The following is a description of a gene set: Genes containing one or more binding sites for (Sox30) in their promoter regions (TSS -1000,+100 bp) as identified by GTRD version 20.06 ChIP-seq harmonization. from publication Yevshin I, Sharipov R, Kolmykov S, Kondrakhin Y, Kolpakov F (PMID 30445619) species: Mus musculus Mouse Gene Set: SOX30_TARGET_GENES, and this is the list of marker genes: Gm5941, Bmp2k, Lrrc8d (NCBI Gene Id 75118), Lsm4 (LSM4 homolog, U6 small nuclear RNA and mRNA degradation associated), Ppa2, H2az2, Ube2v2, Dennd4b, Gm8127, Rnf4, Prdm4, Pacs1 (phosphofurin acidic cluster sorting protein 1), Repin1, Chd5, Prkcz, 0610040J01Rik, Slco6b1, Gm14204, Spata1, Ring1, Fndc3a, Fyb1, Cage1, Coro1c, Dstn, Hdgf, H2bc21, Sun2, 4930554H23Rik, Mrpl45, Gtsf1l, Zfp687, Gabra4, Gm6558, Cry1, Nudc, Gm34106, Mov10l1, Vezt, Gm20474, Glyr1, A230072C01Rik, Srsf11, Zc3h4 (NCBI Gene Id 330474), Gid4, Elovl2, Ero1a, Uba5, Mcts2, Cdc42, Ptpmt1, 4632404H12Rik, Fam178b, Mfsd12, Drap1, Dmrta2, Ppara, Shisa6, Map1lc3a, Sri, Tent5c, Eif5, Bicdl1, Glod4, Aptx, Mir3083, Gm27011, Lmnb1, Nr2f6, Spaca1, Klf15, Josd1, Chd1, Gm6526, Ythdf2, Rybp, Egr3, Nabp1, Exosc3, Usp2, St8sia6, Slc30a4, Dbil5, Spag4, Pnma1, Raver2, Eaf2, Cdkn1c, Adnp, Ica1, Dpy19l1, Fhl3, 1700104B16Rik, Ufsp2, Coro2b, Bop1, Pdcd2, Zfp217, 2610037D02Rik, Otud1 (NCBI Gene Id 71198), Gtf2h5, Sltm, Sphk2, Bbs5, Trafd1, Gm16464, Ube2o, Vldlr, Atpaf2, Prkacb, Cdca7l, Otud4, Nudt3, Adam22, Zfp276, BC034090, Gtf2e2, Prickle1, Gli3, Nelfe, Gabrb3, Dmrta2os, Trim24, Stard10, Ift70a2, Zbtb25, Prpf40a, Cmip, Ccnb2 (NCBI Gene Id 235460), Prpsap1 (NCBI Gene Id 67763, phosphoribosyl pyrophosphate synthetase-associated protein 1), Tubd1, Tulp4, Phospho1, Aff3, Marchf6, Mnt, Siva1, Ash1l, Strbp, Hmgb1, Ppp1r3e, Clgn, Eif4a2, Foxf2, E130317F20Rik, 1110059E24Rik, Chka, Spata7, Ccdc96, Zfp37, Grb10 (NCBI Gene Id 67977), Slc22a23, Dcdc2a, Eif5b, Mex3c, Klhdc3, Papola, Tmem225, Mcl1, Macroh2a1, Bap1, Prdm15, Stac, 4930406D18Rik, Rassf1, Eif4g2, Ddhd1, Vars1, Paxbp1, Wnk2, H2ac18, Fnip2, Gm16576, Dhx15 (DEAH-box helicase 15), Stk11, Mir5131, Shq1, Knop1, Gm20821, Ranbp9, Ugcg, Slc7a5, Phf13, Celf3, Cttnbp2, Gm15908, Ubr2, Adnp2, Sfi1, Tmtc1, Taf5l, Fbxl16, Pwwp2a, Acot4 (NCBI Gene Id 171282), Asxl2, Eif4a1, Txndc9, Dot1l, Radil, H2ac19, Tnpo1, Dazap1, Utp4, Naa40, Camk2b, Dipk1b, Gm14244, Riok1, Bora, 1600020E01Rik, Nmrk1, Paqr9, 1700102P08Rik, Stat5b, 1700096K18Rik, Gm16080, Bola3, Kif24, Tnfsf13os, Smkr-ps, BC048644 (NCBI Gene Id 407789), Usp1, Mgll, Ctag2, Zdhhc5, Msl2, Map4, Ribc2, Pwwp3a, Sort1, Crnde (colorectal neoplasia differentially expressed, non-protein coding), Gnaz (NCBI Gene Id 14687), Pcbp1, Nsg1, Fut8, Psme2, Zgrf1, Hace1, Fkbp7, Mpc2, Hnrnpa2b1, Rnf151, Cdk8, Serac1, Pttg1ip, Tmcc3 (NCBI Gene Id 97668), Enox1, Lrp12, Prkar1b, Arhgap35, Tgfbr2, Zfp523, Rhbdd3, Cct2, Acad11, Appl1, Tle1, Mtx1, Maz, Josd2, Stx11, Hmgn2, Cux2, Crebrf, Gm8212, Smarca4, Fbxo34, Ncl, Ube2d3, Lcorl, Hfm1, Zfp652os, Tfap2a, Rab10os, Gm6556, Ywhaq, 5930403N24Rik, Gm4419, 4930594C11Rik, Cimip4, Gspt2, Cfap276, Ube2e1, Mgat4a, Cacna2d1, Odc1, Gm26397, Mir8109, Anapc10, Gm9059, Dalrd3, Ap1ar, Dtwd2, Rbpj, Zc3h6, Ppp2r5a, Syde2, 4933433G15Rik, Rad17, Pik3cb, Rbm26, Ttc34, Rfc1, Cux1, D030047H15Rik, Rnf113a2, Fbxo46 (F-box protein 46), Cep95, Hnrnpr, Crybg3, Isl1, BC061195, Cypt12, Dnmt3b, Cdv3-ps, Gm42133, Ghitm (NCBI Gene Id 66092), BC030343, 1810010H24Rik, Fbxl13, Usp26, Patz1, Setd2, Kif2a, Tsks, Odf2, Zfp513, Slc27a2, Smad5, Gm2245, Cramp1, Epha5, Tatdn2, Kmt2b, Ralgps2, Ptma, Fcho1, 4930404H24Rik, Klhl7, 1700123M08Rik, Prr23a1, Atp2b1, Yy1, Snu13, Zfp800, Lrrc73, Pals2, Acot7, Ubqln2, Fam228b, Usp13, Wnt7a, Rxrb, Neo1 (NCBI Gene Id 78386), Ppp1r3c, Rps2, 1700010D01Rik (NCBI Gene Id 76386), Tmem53, Prdm11 (NCBI Gene Id 278932), Runx1t1, Noc2l, Kcnb2, Zfp804a, Abi2, Lmo4, Spout1, Tvp23b, Pfn4, Ptbp1, Msantd5l, 4930539J05Rik, Igf2bp3, Ube2e2, Mfsd11, Cct7, 4732463B04Rik, Sfxn4, Cdk13, Gorasp1, Irf2bp2, Gm36527, Setbp1, Aff4, Mlf1, Ube2h, Sncaip, Srsf9, Nfib, Atn1, Cd164, Haus5, 1700031P21Rik, Gm17733, Dapk1, Stau2, Steep1, Nbr1, Ccer1, Slc43a2, Amer2, Nup210, 5430405H02Rik, Tenm2 (NCBI Gene Id 77515), Slc25a38, 4933406P04Rik, Bicral, Rbbp6, Gmfb, Ptpn9, Dzank1, Polr1has, Gm43403, Ube2n, A830082K12Rik, Gm8232, Xpnpep3, Ptgfrn, Hp1bp3, Gjd2, Pura, Pde3b, Mir8104, Zfp36l1, Obsl1, Dbn1, 4930589L23Rik, Kmt5b, Pkdrej, Senp1, Msmo1, Cfdp1, Kcnc1, Pogz, Trp53rka, Mme, Upf1, Mrpl48, Trp53inp2, Stk39, Fsip2l, Yes1, Gm7361, Pts, Gsg1, Irf2bp1, Dpysl2, Lbr, Marchf8, Kics2, Larp7, Osbpl10, Tomm40, Kif17, Gm9694, Allc, Ak6, Zswim5, Zbtb18, Pard3, Sfmbt1, Slc41a2, Gm27211 (NCBI Gene Id 102636126), Gm13238, Wtip, Cypt1, Rheb, A330074K22Rik, Cnr1, Srsf1, Sod1, Dnaja4, Ube4b, Map3k1, Igfbp7, Gm9758, Spaca7b, Ddx5, Shb, Snord110, Coq8b, Hnrnpd, Hhex, Gabrb1, Zbed3, 9230114K14Rik, Rnf144a, Fam98c, Ikzf3, Ift140, Bves (NCBI Gene Id 23828), Mapk6, Hspa4, Arid2, Satl1, Sppl3, Cbfa2t2, Tex30, Med25, Mir6973b, Tob1, Dyrk1b, Crebzf (CREB/ATF bZIP transcription factor), Sptbn1, Kbtbd2, Morc2a, Tax1bp1, Acsl1, Rcor1, Pals1, Usp34, Sde2, Tmem107 (transmembrane protein 107), Hook3, 1700095J07Rik, Bcas2, Ube2q1, Nup93, Gm34086, Plcb4, Nrdc, 4933428P19Rik, Tecr, 4933402J07Rik, Snx24, Trp53rkb, 4930478K11Rik, Urb2, Vps54, Gfpt2, Mthfd2l, Sh2d6, Abhd17b, Zfp184, 4930594M22Rik, Ing1, Mettl25b, Cfap36, Asap1, Tex48, Tex53, Zbtb44, Xpnpep1, Podxl2, Mybl1, Zzz3, Cyp20a1, Tollip, Chd2, 1700028E10Rik, Kansl1, Hipk2, Iqce, Pom121l2, Eef1a1, Kpna4, Src (Rous sarcoma oncogene), Chrna7, Eif5a, 4930579F01Rik, Gm9484, Rbbp4, Ccdc9, Spz1, Hsf1, Fam76a, 1700001L05Rik, 4930417H01Rik, Appbp2os, Bend3, Tmem170b, Ppp1r2-ps3, Gadd45a, Slc4a4, Ddx17, Skp1, Cdca4, Akap14, Ankrd44, Prok2, Ppm1a, Fmnl2, Fdft1, Acadl, 4921536K21Rik, Cse1l (chromosome segregation 1 like), Bambi, Zfp85os, St13, Meiosin, 1700030N03Rik, Hbp1, Adamts19, Tmem250, Atp9b, Commd3, Ubr7, Atxn7l3, Bola1, Mkln1os, Map9, Ptges3, Ctnnb1, Jmjd1c, Dock7, Cpeb2, Casz1, Gm7133, Arl4aos, Pde8b, Gm26588, Lyrm7, Or5k17, Insig1, Cfap96, Armc10 (NCBI Gene Id 67211), 1700009C05Rik, Gm9530, Epc1, Alms1, Dnai3, Sp2, Shcbp1l, Cep112os1, Sec16a, Chaserr, Jph1, C630043F03Rik (NCBI Gene Id 68285), Gmeb2, Ssbp4, Sirt2, Dcun1d4, Anks1b (ankyrin repeat and sterile alpha motif domain containing 1B), AV099323, Senp2, Dusp4, Cbl, Pik3ip1, Srd5a1, Ltbp1, Cdh4, 4933406I18Rik, Epb41, Nkx2-6, Sh3yl1, Tada2b, Adamts8, Atp1b1, Rfx2 (NCBI Gene Id 71404), Ccdc30, Phyhipl, Morf4l1 (NCBI Gene Id 627352), Adipor2, Klhl35, Cct4, Cbx3, Rbpms, Pafah1b1, 4930431P03Rik, Trim33, Zbtb1, Rnf227, Pcna, Cfap20, Nsd2, Msto1, Rnf130, Calm3, Fam131b, Ift88, Jarid2, Ankrd28, Gm3822, Stt3b, Pgm2l1, Ecpas, Abcf2, Cdv3, Nrm, Krt88, Slc16a1, Iqch, 4930526F13Rik, Lrrc8b, Rfng, Afg3l1, Gm7135, Cep350, Lrch1, Mrm3, Snx14, Nop56, Tmem89, 4930449I04Rik, Maml1, Mycbp, Rpl36al, Draxin, Lrp5, Srsf2, Cgnl1, Ptp4a1, Pla2g10, Rnf31, 3110082I17Rik, Aqp7, Anp32e, Gm21190, Gm35065, Cpeb1, Pwwp2b, Rab8a, Tex261, Cd2ap (CD2-associated protein), Eef1d, mt-Tp, Cisd2, Gm15825, Cyp51, Gpx4, Pex5l, Acr, Phf20, Atxn2l, Ccnd3, Ostf1, Hoxd8 (homeobox D8), Colgalt1, Srd5a3, Gm42918, 4930432B10Rik, Tsc22d2, Adgrg6, Slc22a14, Gm21149, Bmi1, Gm21083 (NCBI Gene Id 105242399), Rnf170, Gm6401, Fnbp1l, Ado, Hnrnpab, Arl6ip6, 1700027A07Rik, Fndc3b, Qrich1, Gm15672, Btbd9, Fhl1, Mir7075, Adam12, 0610009E02Rik, Fbxo30, Slc66a2, Brd2, Tbl1xr1, Ermp1, Gas2, Ywhah, Tbc1d31, Agpat2, Nudt2, Mcoln1, Rtn4, G2e3, Tmem97, Faxc, Ndrg3, Tasp1, Dusp12, Fbxo36, Dag1, Rpf2, Lypla1, Map6, Uqcc1, Sacs, Wdr5, Ube2t, Pced1b, Phf24, Brca1, Dctn4, Slc39a7, Zfp87, Tektip1, Sox4, Mospd4, Gm31831, Ttll7, Dipk1a, Gon7, Ftmt, Coa8, Nadk2, 1110002L01Rik, Mapk8ip2, Egln2, Actr1b, Thbs3, Ppp2r3d (NCBI Gene Id 626662), Rab6a, Zfp740, Brpf1, Denr, Gm10731, Tmem67, Scin, Pard6b, Nup42, Pds5a, Grip1, Dyrk1a, Nsun4, Prkci, 4930463O16Rik, Rnf139 (NCBI Gene Id 75841), Psd3, Taf9, Gm16283, 1700019D03Rik, Emx2, Gm5067, Syncrip, Cbln1, Ror2, Hmgcr, Wwp1 (WW domain containing E3 ubiquitin protein ligase 1), Xrcc1, Pstpip2, Nrbp1, Fam220a, Zfand3, Crtc1, Ttc21a, Kcnc4, Ptpn2, Ak1, Rpl24, Mast3, Dap3, Gm12474, Mir3569, 4930439D14Rik, Suv39h2 (suppressor of variegation 3-9 2), Cep120, Gjd2os, C1qbp, Map1a, Slc2a3, Crmp1, Hmgn1, Pinlyp, Mcu (NCBI Gene Id 69874), Foxp1, Gm9962, Pgrmc2, Srcin1, Sik1, Spats2, Atp2c1, Gm1527, Neurl1a, Ccdc126, Zbtb12, Asic1, Hdgfl3, Arfgef1, Unc5d, Lancl2, Trim37, Gm20732, Sumo3, Polr1h, Gps1, Fam81a, Otud7a, Xxylt1, 4933406K04Rik, Gna12, Dusp18, Senp3, Nufip2, Smc1b, Zfp24, Actg1, Frat1, Pdp1, Gpx6, Trmt2a, a, D130017N08Rik, Cmss1, Prr14, Golgb1, 4930520O04Rik, Gpbp1, Gm16506, Bltp2, Mad2l2 (NCBI Gene Id 71890), Msh3, Ptk2, Notch4, Emx2os, Cfap47, Ift74, H2az1, Picalm, Smim27 (NCBI Gene Id 66434, small integral membrane protein 27), Rex1bd, Aif1, Eif4a3, Mir1893, Atf1, Prkd3, Ttll11, Zbed4, Zfp316, Aagab, Dnajc10, Gphn, Tesmin, Gm2449, D5Ertd579e, Frey1, Vkorc1l1, Hspe1, Tmeff1, Ptgr3, Msl1, Gramd4, 4930577N17Rik, Slc25a53, Smg9, Chtf8, Fam209, Efnb2, Dcaf6, 4930562A09Rik, Speer4c1, Htr6, Ptpn13, Zfp384, Gm35025, Hspbp1, Hsf5, Leng8, Tcf12, Thap7, Gm11149, Trim59, Trip12, Peli1, Zfp652, Ggact, Misfa, Gemin4, C130036L24Rik, Sh3rf1, Sik3, Tug1, Cks2, Stxbp5, Ino80e, Gm8540, Arl4a, Ythdc1, H1f9, Dmxl2, Cdkn2aip, Vps9d1, Gng5, Ext1, Gm43391, Stox1, M5C1000I18Rik, Mapre1, Triap1, Gm26608, Uba52, Papss1, Arhgap33, Dipk2a, Gm14232, 0610009L18Rik, Setx, Ranbp1 (NCBI Gene Id 19385), Isg20l2, Pradc1, Speer4e1, Ddx4, Gabrg3, Pdzrn3, Bag5, Catsperg1, 4933424G06Rik, Tef, Elapor1, 4921522P10Rik, Edem1, Acrbp, Mir219c, Zfp821, Zfp58, Ap4m1, Nsun2, Cuedc1, Phf7, Gtf2ird2, Bcl2l1 (NCBI Gene Id 12048), Grsf1 (NCBI Gene Id 97246), Hirip3, Nsmaf, Ubald2, Met, 1700092C10Rik, Ttc7, Zfyve28, Pdzd4, Ankrd9, 1700064H15Rik, Cacybp (NCBI Gene Id 12301), H3f3b, Meig1, Dlx6, Cstf2 (cleavage stimulation factor, 3' pre-RNA subunit 2), Gm17019, Lrba, Ppp1r11, Mcmdc2, Ube2dnl2, Pgap2, Terf2, Cic, Dnajc5b, Akirin1, Pcmt1, A730035I17Rik, 4933417C20Rik, Gm5464, Mir6538, Foxj2, Bcl6, Lrrc74a, Pick1, Rnf138rt1, Smc3, Ttc39d, 4930503E14Rik, Vps37b, Znrf1, Gm13162 (predicted pseudogene 13162), Rsrp1, 4833418N02Rik (RIKEN cDNA 4833418N02 gene), Tut4, Gm16252, Prr16, Camk2d, Skor1, Vapa, Gm15327, Snhg5, Tm9sf5, Marchf10, Specc1, Kpna3, Dhfr, Snx7, Nol4l, Mcm7, Ttc9c, Gatc, Zbtb8os, Ap1g1, Hspa4l, Gm27017, Dnajb12, Plxdc1, Fasn, Sh3gl3, Marcks, Ttc23l, Clk4, Rpl18, 4933408J17Rik, 4930481B07Rik, Atosa, Raly, Shroom3 (shroom family member 3), Rlf, Zfp292, Ptpn4, Cdkn2c, Cbx7, Gatad2b, Ctbp1, Cxxc4, Tcf4, Vash2, 2310010J17Rik, Bmpr1a, Sun5, Skic2, Hnrnpa0, Efhd2